Given this list of marker genes Ankra2 (NCBI Gene Id 68558), Ccdc8, Cul7, Obsl1, Fbxw8, here is a description of the gene set: species: Mus musculus Mouse Gene Set: GOCC_3M_COMPLEX A protein complex, at least composed of CUL7, CCDC8 and OBSL1, that is required for maintaining microtubule and genome integrity.